The following is a description of a gene set: Human Gene Set: HP_BLADDER_DIVERTICULUM species: Homo sapiens Diverticulum (sac or pouch) in the wall of the urinary bladder. Bladder diverticulum, and this is the list of marker genes: COL1A1, EFEMP1, LIMK1, COL1A2, EIF4H, BAZ1B, ATP7A, MLXIPL (MLX interacting protein like), MED12, RFC2 (NCBI Gene Id 5982), GTF2IRD1, EFEMP2, LTBP4, BUD23, PLOD1, GTF2IRD2, ELN, ALDH18A1, COL3A1 (NCBI Gene Id 1281), TBL2, COL5A1, FKBP6, DNAJC30, TP63 (NCBI Gene Id 8860), METTL27, LTBP1, NCF1, FKBP14, VPS37D, TMEM270, STX1A, SALL4, GTF2I, COL5A2, CLIP2, FBLN5